Given this list of marker genes Clba1, Ap1g1, Ap1m1, Ap1s1, Ap1s2, Cltc, Ap1g2, Ap1m2, Synrg, Ap1b1, Aftph, Clta, Cltb, Ap1s3, Slc18a3, here is a description of the gene set: Mouse Gene Set: GOCC_CLATHRIN_COAT_OF_TRANS_GOLGI_NETWORK_VESICLE A clathrin coat found on a vesicle of the trans-Golgi network. studied in species Mus musculus